The following is a description of a gene set: from publication Mori S, Rempel RE, Chang JT, Yao G, Lagoo AS, Potti A, Bild A, Nevins JR (PMID 18922927) Mouse Gene Set: MORI_PRE_BI_LYMPHOCYTE_UP The Emu-myc transgenic mouse has provided a valuable model for the study of B-cell lymphoma. Making use of gene expression analysis and, in particular, expression signatures of cell signaling pathway activation, we now show that several forms of B lymphoma can be identified in the Emu-myc mice associated with time of tumor onset. Furthermore, one form of Emu-myc tumor with pre-B character is shown to resemble human Burkitt lymphoma, whereas others exhibit more differentiated B-cell characteristics and show similarity with human diffuse large B-cell lymphoma in the pattern of gene expression, as well as oncogenic pathway activation. Importantly, we show that signatures of oncogenic pathway activity provide further dissection of the spectrum of diffuse large B-cell lymphoma, identifying a subset of patients who have very poor prognosis and could benefit from more aggressive or novel therapeutic strategies. Taken together, these studies provide insight into the complexity of the oncogenic process and a novel strategy for dissecting the heterogeneity of B lymphoma. studied in species Mus musculus Up-regulated genes in the B lymphocyte developmental signature, based on expression profiling of lymphomas from the Emu-myc transgenic mice: the Pre-BI stage., and this is the list of marker genes: Mcm2 (NCBI Gene Id 17216), Slc29a1, Ankrd33b, Ncaph, H2ac6, Phgdh, Hnrnpab, Smarcc1, Txn1, Rad51, Ttk, Cdk1, Mcm6, Tubb4b, Gm13394, Ssbp4, Rbbp4, Tubb5, Lef1, Prdx4, Socs2, E2f8, Top2a, H2az2 (H2A.Z histone variant 2), Hmgn2, Rrm1, Aurka, Lmnb1, Cdkn1a, Sqle, Mki67, Ccl5 (C-C motif chemokine ligand 5), Ide, Ran, Rasa4, Cdca3, H2ax, Adgrg3, Cdc20, Emp1 (epithelial membrane protein 1), Fcer1g, Ccnb2, Hspbp1, Mthfd2, Hjurp, Ramp1, Emb, Prc1, Kif4, Lig1, Gzma, Dbi, Tuba1b, Ube2c, Smc4, Cdca5, Cdca7, Mgst2, Kpna2, Igll1, Nucks1 (nuclear casein kinase and cyclin-dependent kinase substrate 1), Melk, Mif, Enpep, Psat1 (phosphoserine aminotransferase 1), Cks1b, Hmgb3, Dtl, Kank3, Rrm2, Mpeg1, Racgap1, Anp32e, Gstt2, Mcm7, Eng, Stmn1, Actn4, Dntt, Tuba1a, Grb7